The following is a description of a gene set: Catalysis of the reaction: an alditol + NADP+ = an aldose + NADPH + H+. studied in species Mus musculus Mouse Gene Set: GOMF_ALDOSE_REDUCTASE_NADPH_ACTIVITY, and this is the list of marker genes: Akr1d1, Akr1c21, Akr7a5, Akr1b10, Akr1a1, Adh4, Akr1c14, Akr1c12, Akr1cl, Akr1c13, Akr1b8, Akr1b7, Akr1e1, Akr1c18, Akr1c20, Akr1b1, Akr1c6, Akr1c19